The following is a description of a gene set: species: Homo sapiens Genes down-regulated in comparison of effector CD8 T cells versus memory CD8 T cells. Human Gene Set: GSE9650_EFFECTOR_VS_MEMORY_CD8_TCELL_DN from publication Wherry EJ, Ha SJ, Kaech SM, Haining WN, Sarkar S, Kalia V, Subramaniam S, Blattman JN, Barber DL, Ahmed R (PMID 17950003) CD8 T cells normally differentiate from resting naïve T cells into function effector and then memory CD8 T cells following acute infections. During chronic viral infections, however, virus-specific CD8 T cells often become exhausted. We used microarrays to examine the gene expression differences between naive, effector, memory and exhausted virus-specific CD8 T cells following lymphocytic choriomeningitis virus infection., and this is the list of marker genes: DDX6, HSD17B11, NLK, ODC1, HSPA9, GART, MYCBP2, ETS2, SIAH2, MIDN, CDK4, RREB1, PRNP, HEXA, TLR6, SLC3A2, JUND, MRPL23, RPS4X, RETREG1, CTSS, BNC1, D2HGDH, ADI1, HSD17B8, SIPA1L2, ZFP36L2, MYPOP, KANSL2, CD7, ARRB1, PIM2, RPL6, XRCC5, VRK1, RABAC1, SNTB2, GALNT11, PCM1, PABPC4, LONP1, C19orf48P, ZBTB20, CD2AP (CD2 associated protein), EYA2, ERCC5, TRAF1, NOP56, HSP90AB1, SLC30A1, TP53, PHF12, RCL1, SPRED2, NFKBIZ, NR1D2, CRP, ZKSCAN3, ARID1A, VKORC1, SLC44A1 (solute carrier family 44 member 1, NCBI Gene Id 63942), IL7R, C3AR1, FBL, GATA3, TAPBP, PNRC1, TENT5C, MBP, H19, GAR1, CCND2, RGS2, ENTPD5, ARL4C, PARP8, IFT172, FOSB, MFN1, PDK1, TOB1, RPS6, RPGR, SELL, IFNG, SLC11A2, GNL3, BCL2, SESN1, PIM1, RHOB, MYC, RPL5, EEIG1, ZNRF1 (NCBI Gene Id 84937), GADD45A (NCBI Gene Id 1647), KLF6, RGS10, LARP1, HPCAL1, BTG1, CCR7, XPC, TOMM34, POU6F1, IL4R, ZFP36, APEX1, SORL1, SLC12A7, FMC1, RPS19 (NCBI Gene Id 8378), AFM, AQP9, RNF141, NPM1, RNF38, ATP13A1, DEDD, NR2C1, NEDD4L, SRSF7, SATB1, FOS, NUMA1, HSPE1, PAM, RERE, P2RX4, NOTCH1, RBM39, TCF7, UCK1, TNFSF8, HNRNPA1, NDUFAF4, CAMSAP1, PLEKHA1, AKAP9, KLF4, CD72, ITPKB, CXCR3, SMAD7, EIF2S2, RGCC, PKD1, GRWD1, IPO4, AXIN1, EVL, DYM, CDR2, BCKDHB, EIF1 (eukaryotic translation initiation factor 1), DDX5, TSR1, KCTD12, VAMP2, LAMP1, MOGS, RPL14, SOCS3, METTL1, GSTO1, DNAJB2, MCOLN2, RFLNB, IFRD2, ZSCAN26, TDRP, IL6R (NCBI Gene Id 3570), ABCG1, NNT, KCNJ8 (potassium inwardly rectifying channel subfamily J member 8), LUC7L, SKI, PRSS12, SSBP2, DUSP6, OVGP1, DPH5, IDUA, CNR2, ZMIZ2, SMAD1, DALRD3, JUN, CAPRIN2, DDX47, DUSP1, NME1, NSG2, DNAAF10, HDAC7, EIF5, LMO4, ADRB2, IFNAR2, RPS3